Given this list of marker genes NSD2, BYSL, PI3, GAD1, CDCA5, XPO5, FAR2, KCNE3, NUDCD1, MRPS28, MUC3A, MARVELD3, CENPK, SKA3, ARPC4, DCAF13, CXCL5, SGO2, PRR11, TTK, CLRN3, BUB1B, RUVBL2, MCM4, NUP155, MIRLET7BHG (NCBI Gene Id 400931), PFKP, ASS1, CKS1B (NCBI Gene Id 88475), MRPS17, S100A10, ESCO2, NAA25, SAC3D1, MYBL2, IL15RA, PBK, RACGAP1, ATP11A, MRTO4, POP7, IL17RB, WDR72, KIF14, MYOF, CAMK2N1, TMPRSS4, WDR90, NUDT6, CDC6, NUP62CL, BUB3, GTSE1, CCT6P3, CHI3L1, PARPBP, CEP72, BARD1, BRCA1, NSUN5, TK1, MUC13, CKS2, MTHFD1L, CDC20, CENPW, SATB2-AS1, RASGEF1A, MAD2L1, CSPG5, TRUB2, CDC25B, IER5L, NPM1, FOXP4-AS1 (FOXP4 antisense RNA 1), KDM1B, SPP1, GSTCD, ASPM, E2F8, EIF3B, LAMA3, STAMBPL1, BOK, HSPB1, COL7A1, RAD51AP1, MYB, ALYREF, CLDN7, ITGA2, RAD54B (NCBI Gene Id 730560), SFR1, SNX5, MELTF, PRPF4, FOXM1, GPRC5A, MRPS10, RAD18, EZH2, GTPBP4, NUP58, DUXAP8, PUS7, GLRX3P2, DGKH, TMEM45B, EFTUD2, LACTB2, INTS2, NCAPG2, WRNIP1, GDF15, TMED9, SHKBP1, EBNA1BP2, UCHL3, CLDN2, ARHGAP8, DTL, CDK12, ABHD11, DPP3, FANCI, NCBP2, BIRC5, ABHD12, SPDL1, CCNA2, PTMA, MMP3, MCM7, KLK10, TMEM68, NUP93, FOSL1, FEN1, FAM50A, SPIN4, RBM19, CCNE1, CRIP1, DKC1, ANLN, ATP10B, PGRMC1, TRIP13, JPH1, SFXN4, FAM72C, PDP1, TBCB (tubulin folding cofactor B), CKAP2, MRPS16, ZNF792, NOP56, PSMB8, AGO2, CXCL1, CENPF, EFNA2, CDK1, PITPNB, SHANK3, CTSB, ZIC2, TRMT6, TPX2, JPT2, DHX8, SCRIB, UPP1, HMMR, RBM42, MIPEP, SLC39A4, TIMM13, LAMA5, POLD3, STK31, CDC34, MACC1, SLC4A11, XRCC4, PDZK1IP1, VARS1, TOP2A, MTFR2, ISG15 (NCBI Gene Id 9636), FANCD2, CALML4, NMU, CCNB1, NEK2, PTMAP4, DSCC1, EPPK1, ZNF511, KLK6, RNF123, NELFCD, C8orf33, ZNF367, KIF20A, LCN2, S100A6 (S100 calcium binding protein A6), RARRES1, ENO1, SNORD104, DEPDC1, NUF2, FAM133B, PTRH1, CXCL3, KIF26B, PRELID1, RPN1, FIGNL1, MSRB1, UBE2T, MYEOV, SKP2, ACAA2, CSTF3, S100A11, RPL8, CDCA2, HOXA10, ILDR1, COMMD5, KICS2, KLF5, LYAR, ZNF117, RPA3, TACSTD2, BRIP1, MIR17HG, PHF20, AATF, LAMC2, NPIPA1, LRP8, AJUBA, AIFM2, SPTAN1, KIF9, THOC3, ITPA, LIF, CDR2L, RRS1, PIEZO1, KLHL21, BUB1, RRM2, MMP7, CCNB2, CDH3, CDCA7, SMC4, INHBA, CBX2, LINC-PINT, FERMT1, ATAD2, HSPE1, ANKRD10, CDH17, ARL5B, TFAP2A, GINS4, HMGA1, NEAT1, MCF2L, SAMD5, ZNF592, IFITM1, MTCH2, FBXO32, GUCY2C, MCM2, DHFR (NCBI Gene Id 203373), CENPU, UBE2C, BID, MELK, ANP32E, HOXC6, NTPCR, SDHAP1, MKI67, KRT7, ECT2, MRPL13, SNRPD1, SMARCA4, WDR77, MAGEA3, HUS1, NASP, UTP4, UHRF1, SEMA4B, DEPDC1B, SLC28A3, RBM26, CXCL8, KRT18, ZWINT, TNRC18, ADAT2, CFTR, MSX2, KMT2E-AS1, CHEK1, HSPA8, RANBP1, STK3, HMGB3, GGH, JUP, PFDN4, HSPH1, PTTG1, GRN, SLC52A2, EPHB2, GABBR1, CEP55, KLK7, EPHA1-AS1, APEX2, JPT1, LAPTM4B, KIF18B, TRIM31, EFNA4, CDK6, POP1, CEMIP, PROX1, FUBP1, AURKA, TMC5, ZDHHC11, KIF4A, IFITM2, RP9, KNL1, DLGAP5, NOP16, PRC1, PCBD1, H19, GAS5, CLN8, MCM5, PDCD6, MYG1, CD9, ZFAS1, ABHD10, NUSAP1, RPS21, NDC80, PDSS1, CPLX1, SNHG4, STRIP2 (striatin interacting protein 2), GINS1, CENPH, EML4, CYC1, SNRPB, CDKN3, NPM1P22, SLC39A10 (solute carrier family 39 member 10), GSS, F12, SPMIP6, ADORA2B, SLC6A8, E2F7, NME1, IFI6, PFDN2, ATG16L1, TFAP2C, VPS50, SOD2 (superoxide dismutase 2), NCAPG, POLR2G, PCLAF, CENPA, TIMM17A, PRMT1, SHQ1, ASCL2, KIF15, PABPC1L, TMEM158, CSE1L, CENPN, RUNX1, HMGB1 (high mobility group box 1), GPSM2, DLEU2, FAM83H, IDH3B, IFITM3, TRIM47, SCYL1, MCM10, CLDN3, KCNN4, CLDN1, FBXO31, MZT1, SMARCE1, HOXA9, RFC3, TUBA4A, TM4SF1 (transmembrane 4 L six family member 1), BMS1, SPIDR, ZFP41, ZNF703, CTSV, OVOL1, CENPM, CCT3, PMEPA1, GINS2, PSMA7, here is a description of the gene set: from publication Vecchi M, Nuciforo P, Romagnoli S, Confalonieri S, Pellegrini C, Serio G, Quarto M, Capra M, Roviaro GC, Contessini Avesani E, Corsi C, Coggi G, Di Fiore PP, Bosari S (PMID 17297478) studied in species Homo sapiens Human Gene Set: VECCHI_GASTRIC_CANCER_EARLY_UP Gastric carcinoma is one of the major causes of cancer mortality worldwide. Early detection results in excellent prognosis for patients with early cancer (EGC), whereas the prognosis of advanced cancer (AGC) patients remains poor. It is not clear whether EGC and AGC are molecularly distinct, and whether they represent progressive stages of the same tumor or different entities ab initio. Gene expression profiles of EGC and AGC were determined by Affymetrix technology and quantitative polymerase chain reaction. Representative regulated genes were further analysed by in situ hybridization (ISH) on tissue microarrays. Expression analysis allowed the identification of a signature that differentiates AGC from EGC. In addition, comparison with normal gastric mucosa indicated that the majority of alterations associated with EGC are retained in AGC, and that further expression changes mark the transition from EGC to AGC. Finally, ISH analysis showed that representative genes, differentially expressed in the invasive areas of EGC and AGC, are not differentially expressed in the non-invasive areas of the same tumors. Our data are more directly compatible with a progression model of gastric carcinogenesis, whereby EGC and AGC may represent different molecular stages of the same tumor. Finally, the identification of an AGC-specific signature might help devising novel therapeutic strategies for advanced gastric cancer. Up-regulated genes distinguishing between early gastric cancer (EGC) and normal tissue samples.